Given this list of marker genes P4HA2, MYH11, PTPN22, BGN, SMAD4, THSD4, ELN, ENG, GATA5, MYLK, THSD1 (thrombospondin type 1 domain containing 1), TGFB3, IPO8, SMAD3, PLOD1, ANGPTL6, FBN1, HLA-B, ROBO4, SMAD6, NKX2-5, ACTA2, FOXE3, HEY2, SLC2A10, PRKG1, LOX, COL3A1, TGFBR3, EMILIN1, HLA-DRB1, MFAP5, TGFB2, TGFBR2, MAT2A, TGFBR1, ENPP1, NOTCH1, SMAD2 (NCBI Gene Id 654050), ABCC6, here is a description of the gene set: Aortic dissection studied in species Homo sapiens Aortic dissection refers to a tear in the intimal layer of the aorta causing a separation between the intima and the medial layers of the aorta. Human Gene Set: HP_AORTIC_DISSECTION